The following is a description of a gene set: species: Homo sapiens Human Gene Set: HP_ABNORMAL_HUMERAL_METAPHYSIS_MORPHOLOGY Abnormal humeral metaphysis morphology, and this is the list of marker genes: STX16, TRPV4, EZH2, GNAS, GNPNAT1